The following is a description of a gene set: Any process that modulates the rate, frequency or extent of a chemokine-mediated signaling pathway. Mouse Gene Set: GOBP_REGULATION_OF_CHEMOKINE_MEDIATED_SIGNALING_PATHWAY studied in species Mus musculus, and this is the list of marker genes: Sh2b3, Rnf113a1 (NCBI Gene Id 69942), Trem2, Slit3, Robo1, Slit2, Rnf113a2, Ccl5, Padi2, Hif1a, Edn1